Given this list of marker genes Rab5if, Nomo1, Tmem147, Wdr83os, Tmco1, Ccdc47, Ncln, here is a description of the gene set: studied in species Mus musculus Mouse Gene Set: GOBP_MULTI_PASS_TRANSMEMBRANE_PROTEIN_INSERTION_INTO_ER_MEMBRANE A process of protein insertion of multi-pass membrane proteins into the endoplasmic reticulum (ER) membrane. Insertion of multi-pass membrane proteins is mediated by the multi-pass translocon complex and takes place following membrane insertion of the first few transmembrane segments of proteins by the SEC61 complex to promote insertion of subsequent transmembrane regions.